The following is a description of a gene set: from publication Chen Y, Wang X (PMID 31504780) studied in species Homo sapiens Genes predicted to be targets of miRBase v22 microRNA hsa-miR-4787-5p in miRDB v6.0 with MirTarget v4 prediction scores > 80 (high confidence targets). Human Gene Set: MIR4787_5P, and this is the list of marker genes: LRRC3B, ARID2, INF2, SPTSSA, CEMIP2, ZNF385A, PDLIM5